Given this list of marker genes HADHB, SDHAF1, TAFAZZIN, MT-TE, COMP, SDHB, PNPLA2, HADHA, ALDOA, SDHA, SDHD, here is a description of the gene set: Human Gene Set: HP_SKELETAL_MYOPATHY studied in species Homo sapiens Skeletal myopathy